The following is a description of a gene set: species: Mus musculus An intracellular signaling cassette in which the signal is passed on within the cell by nitric oxide (NO) activating soluble guanylyl cyclase (sGC). Includes synthesis of nitric oxide, guanylyl cyclase activity, and downstream effectors that further transmit the signal within the cell following activation by cGMP. Mouse Gene Set: GOBP_NITRIC_OXIDE_CGMP_MEDIATED_SIGNALING, and this is the list of marker genes: Cd36, Gucy1a1, Kdr, Nos1, Agtr2, Ins2, Gucy1b1, Apoe, Thbs1, Ins1, Kcnc2, Atp2b4